The following is a description of a gene set: Mouse Gene Set: GOMF_UBIQUITIN_LIKE_PROTEIN_BINDING Binding to a small conjugating protein such as ubiquitin or a ubiquitin-like protein. studied in species Mus musculus, and this is the list of marker genes: Dcun1d3, Fbxo7, Otub2, Hspb1, Nbr1, Map3k7, Usp16, Tes3-ps, Otulinl, Mdm2, Birc2, Ubap1, Trp53inp2, Tollip, Cks1brt, Rnf31, Ubxn11 (UBX domain protein 11), Sirt2, Dhx16, Dcun1d1, Rad23a, Nod1, Plaa, Sobp, Uchl3, Rnf19b, Sprtn, Ubap1l, Faf2, Smarcad1, Amfr, Cuedc2, Dnaaf10, Ubr5, Ube2n, Cuedc1, Ube2l6, Tdg-ps, Casp8ap2, Dcun1d5, Marchf7, Top2a, Pml, Tsg101, Vps28, Uchl4, Gga2 (golgi associated, gamma adaptin ear containing, ARF binding protein 2), Klf1, Tab3, Stam2, Rnf185, Usp5, Serbp1, Otub1, Rnf4, Eps15, Uevld, Ubxn2a, Usp25, Herc2, Ubxn2b, Ubxn10, Zcchc12 (NCBI Gene Id 72693), Rnf111, Rad23b, Gga1, Rae1, Tdg, Vps36, Sqstm1, Ubxn1, Habp4, Ubxn7 (NCBI Gene Id 381042), Trim32, Tom1l1, Uchl1, Prkn, Mvb12a, Faap20, Ascc2, Aup1, Zfand2b, Hgs, Simc1, Rnft1, Ddi2, Wdr48, Dcun1d4, Nedd4, Fbxw7, Sharpin, Uspl1, Dnajb2, Nsfl1c, Smad3, Optn, Rbck1, Ikbkg, Faf1, Tab2, Stam, Jarid2, Cbx4, Tom1 (target of myb1 trafficking protein), Bub3, Dcun1d2, Pelp1, Ilrun, Rnf168, Nploc4, Hdac6, Cks2, Tnfaip3, Nup62, Usp13, Uba2, N4bp1, Tom1l2, Tax1bp1, Cks1b, Gga3, Nod2, Rnf8, Ubxn8, Cxcr4